The following is a description of a gene set: Human Gene Set: GOBP_HYPOTHALAMUS_CELL_MIGRATION The directed movement of a cell into the hypothalamus region of the forebrain. species: Homo sapiens, and this is the list of marker genes: PLXNA1, PITX2, SEMA3E, NDNF, FOXB1, NRP2, PLXNA3, NRP1